The following is a description of a gene set: The process in which an antigen-presenting cell expresses antigen (peptide or lipid) on its cell surface in association with an MHC protein complex. Mouse Gene Set: GOBP_ANTIGEN_PROCESSING_AND_PRESENTATION studied in species Mus musculus, and this is the list of marker genes: H2-T3, Tap1, H2-Ob, H2-T24, Fcgr1, Ctss, Marchf1, Rab27a, Cd1d2, Fcer2a, Flt3, Fam3d (FAM3 metabolism regulating signaling molecule D), Azgp1, Tapbp, Ap3d1 (NCBI Gene Id 11776), Ccl21a, H2-Q1, Ext1, B2m, H2-M10.2, H2-Q6, H2-Aa, Pycard, Relb, Washc1, Fcgr3, Tap2, Rab35, H2-M10.3, H60c, Psmb9, Mfsd6, Rftn1, Ulbp1, Psme1, H2-M10.1, Tapbpl, H2-M3, Ccl19, Fcer1g, H2-M10.5, Psmb8, Rab34, Ighm, Fcgr2b (NCBI Gene Id 98391), H2-M10.6, H2-K1, Raet1d, Ythdf1, Rab33a, H60b, Nod1, H2-T23, Ccr7, H2-T22, Atg5, H2-M5, Marchf8, Ap3b1, Ighe, H2-T13, H2-Q7, H2-DMb2, Rab6a, Kdm5d, Hfe (homeostatic iron regulator), Cd68, Fgl2, H2-M9, Rab4a, Traf6, Rab32, H2-T15, H2-D1, Lgmn, Abcc1, H2-DMb1, Thbs1, Clec4b2 (NCBI Gene Id 381809), H2-T5 (NCBI Gene Id 667977), Nod2, Was, H2-M2, Rab5b, Rab10, H2-Eb1, Rab8b, H2-M1, H2-Q10, Ide, H2-Eb2, Cd1d1, Unc93b1, Clec4a2, H2-Oa, Trem2, Slc11a1, H2-DMa, Icam1, Pikfyve, H2-Q4, Fcgr4, Calr, Trex1, Rab3c, Mpeg1, Psap, H2-M11, 2410137M14Rik, Ctsl, Cd74, Bag6, H2-Q2, Ctse, Ptpn22, Wdfy4 (NCBI Gene Id 545030), H2-M10.4, Raet1e, Mr1, Pdia3, H2-Ea, Rab3b, H2-Ab1, Clec4a3, Ifng, Ifi30, Treml4, Gba1, Clec4a4, Psme2, Arl8b